The following is a description of a gene set: Gap junction degradation studied in species Homo sapiens Human Gene Set: REACTOME_GAP_JUNCTION_DEGRADATION, and this is the list of marker genes: AP2M1, ACTB, DNM1, ACTG1, MYO6, DNM2, CLTC, DAB2, GJA1, CLTA, CLTB, CLTCL1